The following is a description of a gene set: species: Homo sapiens Human Gene Set: chr3q26, and this is the list of marker genes: ACTG1P23, SLC31A1P1, FGFR3P4, GNB4, ENSG00000200288, MTND5P15, PSMC1P7, MMACHCP1, KCNMB2-AS1, NDUFB5, ENSG00000287605, RNU4-38P, CLDN11, MIR1263, SOX2, ENSG00000289884, MATR3P2, MIR7977, MIR551B, DCUN1D1, NMD3, LINC01208, ASS1P7, PDCD10, LINC01994, ATP11B, RPS27AP8, KRT18P43, RNU6-1317P (RNA, U6 small nuclear 1317, pseudogene), BZW1P1, GPR160, RNU6-547P, SEC62-AS1, RNU1-70P, RNF13P1, SAMD7, RPL28P1, LINC01327, LINC00501, LINC02015, ZCCHC10P1, ACTRT3, MTND4LP10, RALBP1P1, NAALADL2, OTOL1, TBL1XR1, RN7SL229P, EGFEM1P, TMEM229BP1, EI24P6 (EI24 pseudogene 6), RNU6-1120P, RN7SKP265, SLC2A2, DNAJC19, LINC01997, TMEM38BP1, GAPDHP36, KCNMB3, DDX5P1, MFN1, LINC02053, SLITRK3, MCUR1P2, LINC01014, TMEM212, SERPINI1, NLGN1, ENSG00000239096, PHC3, SRP14P5, SERPINI2, B3GALNT1 (NCBI Gene Id 8706), ENSG00000240497, RPL23AP42, LRRC31, RPL22L1, KMT5AP3, TNIK, PSAT1P4, CCDC39, RPL32P10, EIF3EP4, RPL21P43, GHSR, SLC7A14, FAM20BP1, MTCO1P58, NAP1L5P1, TERC, MECOM, SKIL, FXR1, MRPL47, RPSAP33, TBL1XR1-AS1, WDR49, PSMG3P1, SPATA16, ECT2, RNA5SP147, RPL7L1P8, RN7SKP234, ZMAT3, SOX2-OT, RNU6-4P, RN7SKP52, PPIAP74, NAALADL2-AS1, PLD1, LINC01322, SEC62, EIF5A2, ACTBP16, UBE2V1P2, TOMM22P6, LINC02031, ENSG00000201957, MYNN, PLA2G10P1, RPL22P1, USP13, RNU6-486P, ANAPC15P2, LINC02068, MECOM-AS1 (MECOM antisense RNA 1), LINC01326, TTC14, ATP11B-DT, RN7SL703P, CYCSP56 (NCBI Gene Id 107986039), H3P13, RNA5SP148, LRRIQ4, ENSG00000201810 (NCBI Gene Id 124900551), BCHE, RNU7-82P, KCNMB2, RNU4-4P, RNU6-348P, RNA5SP149, MTHFD2P7, PEX5L-AS1, MIR4789, LINC02023, LINC01192, RNU6-681P, RPS6P4, EEF1GP4, TMEM212-IT1, FNDC3B, CCDC39-AS1, ZNF639, PSMG3P2, SPTSSB, KLF7P1, LINC02082, C9orf85P2, FAUP2, LRRFIP1P1, MIR569, KRT8P13, SLC7A14-AS1, PPIAP75, SNORA72, ACTL6A, HMGN2P26, LRRC77P, PRKCI, PIK3CA, RN7SL141P, TBPL1P1, EI24P1, GOLIM4, FLYWCH1P1, SSBL6P, TMEM212-AS1, RN7SKP298, NCEH1, ENSG00000285336, RNU6-1233P, TTC14-DT, MTND3P7, LINC02067, LINC01206, CBX1P5, NGRNP1, RNA5SP150, MTCO3P38, RNU2-20P, ZBBX, MTND4P17, MIR6828, EIF4EP3, LRRC34, RPL29P34, LINC00578, ATP5MC1P4, RNU4-91P, LINC01209, LINC01324, HMGN1P8, PEX5L, RNU6-315P, RPL7AP25, RN7SKP40, RNU6-637P, PIK3CA-DT, FHL1P1, EEF1B2P8, SDHDP3, TNFSF10, NAALADL2-AS2, SI, MEMO1P3, RPL8P4, NLGN1-AS1, NAALADL2-AS3, PEX5L-AS2